The following is a description of a gene set: species: Homo sapiens The dissolution of the nuclear membrane marks the beginning of the prometaphase. Kinetochores are created when proteins attach to the centromeres. Microtubules then attach at the kinetochores, and the chromosomes begin to move to the metaphase plate. Reactome Pathway: Mitotic Prometaphase part of: M Phase, and this is the list of marker genes: RANBP2, TUBG2, YWHAE, CCNB1, FIRRM (FIGNL1 interacting regulator of recombination and mitosis), CENPL, PPP1CC, PPP2R5D, BUB1B, AURKB, TUBB4B, CEP63, CEP152, CENPT, KIF2B, HAUS7, CDK1, CDCA5, CEP70, HAUS5, CEP72, TUBGCP2, ACTR1A (NCBI Gene Id 10121), TUBB1, TUBB2A, CCP110, ALMS1, DYNC1H1, PPP2R5B, AHCTF1, CENPQ, CENPS, TUBB3, HSP90AA1, CDK5RAP2, NINL, TUBB2B, TUBGCP3, NEK7 (NCBI Gene Id 148565), NDEL1, B9D2, PLK1, CKAP5, PCNT, CEP135, DYNC1LI1 (dynein cytoplasmic 1 light intermediate chain 1), CPAP, SSNA1, PPP2CB, NUF2, YWHAG, CENPK, SMC1A, CNTRL, TUBB8, OFD1, TUBGCP6, CEP57, CDCA8, NUP133, CSNK2B, ERCC6L, DYNC1LI2, TUBAL3, CENPM, CEP164, MAD2L1, MZT1, DYNC1I1, SFI1, KIF2C, MAPRE1, SKA2, SEC13 (NCBI Gene Id 6396), CEP78, PAFAH1B1, SDCCAG8, ZWINT, NUP160, WAPL, DYNLL1, DCTN3, CEP43 (centrosomal protein 43), SMC2, CENPO, CENPU, TUBGCP4, CEP131, TUBB, CLIP1, BUB3 (BUB3 mitotic checkpoint protein), BUB1, TUBGCP5, MZT2B, SGO1, TUBA1B (tubulin alpha 1b), PPP2R1A, HDAC8, EML4, PPP2CA, SPC24, MAD1L1, CENPE, NCAPD2, NUP37, HAUS3, SKA1, CLASP2, CETN2, KNTC1, CENPI, PCM1 (NCBI Gene Id 5108), CSNK1D, INCENP, CEP41, MZT2A, PRKAR2B, RAD21, SEH1L, CENPH, TUBA8, PRKACA, NUMA1, PPP2R5E, CENPC, TUBA1A, SPC25, KNL1, NDE1, STAG2, DCTN1, SPDL1, HAUS6, PPP2R5A, RANGAP1, XPO1, NCAPH, TAOK1, CLASP1, ZWILCH, PDS5B, AKAP9, DYNLL2 (dynein light chain LC8-type 2), TUBA4A, HAUS1, CDC20, SMC3, SGO2, STAG1, NEK6, DYNC1I2, NUDC, TUBB8B, CEP250, NEK9 (NCBI Gene Id 91754), PPP2R1B, CEP76, KIF18A, TUBA4B, TUBB6, ZW10, NUP107, HAUS8, NDC80, TUBA3E, TUBB4A, CENPN, TUBA3D, PPP2R5C, NEK2, NUP43, HAUS4, TUBG1 (tubulin gamma 1), CENPA, MIS12, TUBA3C (NCBI Gene Id 7278), CSNK2A1, NUP98, HAUS2, DSN1, NME7, PDS5A, NUP85, CSNK2A2 (NCBI Gene Id 650690), SMC4, RCC2, CEP290, PMF1, BIRC5, PLK4, CENPP, KIF2A, NSL1, CEP192, TUBA1C, NEDD1, DCTN2, ITGB3BP, CSNK1E, ODF2, CCNB2, RPS27, CENPF, NCAPG